The following is a description of a gene set: species: Homo sapiens Human Gene Set: GSE14769_20MIN_VS_360MIN_LPS_BMDM_UP The innate immune system is a two-edged sword; it is absolutely required for host defense against infection, but if left uncontrolled can trigger a plethora of inflammatory diseases. Here we used systems biology approaches to predict and validate a gene regulatory network involving a dynamic interplay between the transcription factors NF-κB, C/EBPδ, and ATF3 that controls inflammatory responses. We mathematically modeled transcriptional regulation of Il6 and Cebpd genes and experimentally validated the prediction that the combination of an initiator (NF-κB), an amplifier (C/EBPδ) and an attenuator (ATF3) forms a regulatory circuit that discriminates between transient and persistent Toll-like receptor 4-induced signals. Our results suggest a mechanism that enables the innate immune system to detect the duration of infection and to respond appropriately. Genes up-regulated in comparison of macrophage cells stimulated with LPS (TLR4 agonist) for 20 min versus macrophage cells stimulated with LPS (TLR4 agonist) for 360 min. from publication Litvak V, Ramsey SA, Rust AG, Zak DE, Kennedy KA, Lampano AE, Nykter M, Shmulevich I, Aderem A (PMID 19270711), and this is the list of marker genes: NME4 (NCBI Gene Id 4833), JPT2, DPP8, SPDL1, PLIN2, DYM, ORC2, LYL1, PSRC1, SELENBP1, TYROBP, PTGR2, ANAPC7, DTYMK, ANGPTL2, IMPA1, MAF1, NT5C, SAMM50, POP5, AKR1B1, AP5S1 (NCBI Gene Id 55317), BET1, NXT2, MBP, WDR7, CAMK1, PPP5C, BTBD3, CXorf38, EVI5, FDXR, GNA12 (G protein subunit alpha 12), NCAPD2 (NCBI Gene Id 9918), FAM78A, ZDHHC3, FBXL17, SLC35E2B, NSD2, GINS3, ANTXR2, FRRS1, TRIM44 (tripartite motif containing 44), RAB3IL1, NEIL3, ARHGDIB, CASP2 (caspase 2), BAG4, CRTAP, IARS1, LIPA, WDR5, EBPL, IGHM, PIK3CG, COMMD10, E2F1, SLC41A2, G3BP1, MFSD12, GORASP1, APOO, EEF1B2 (eukaryotic translation elongation factor 1 beta 2), POLG2, KIAA0930, EEF2K, CYP20A1, CMC2, PXMP4, S100A6, PHKA2, OTUD6B, DYRK1A, CTSA, IGF1, TIMM21, ZBTB14, HADH (hydroxyacyl-CoA dehydrogenase), ZZZ3, CLN8, MDH1, PUS1, ATP11C, TM6SF1, CNOT8, CDIN1, RAB11FIP2, AP2S1, NCAPH, ING2, STN1, MRPS33, WFIKKN1, MCM4, SLC39A12, MLF1, KCTD17, CD9, NQO2, NDUFS1, HAUS1, PSPH, GNAQ, PDCL, USP28, POLD1, CCDC47, SEPHS2, PDLIM4 (NCBI Gene Id 8572), TSFM, SDHA, TUBE1, ACAT1, TMEM97, FKBP1A, NAV2, MCEE, TSEN2, RPS2, ATP6V0D2, CDK19, PRPSAP2, SLF1, IFTAP, UBE2U, SUOX, POLR2F, SNCAIP, LPCAT3, ASF1B, DDI2, INTS10, VTI1B, COX7A2, ATP5F1C, ENTPD4, MKNK1, GOLIM4, DHODH, DOCK1, POLR3G, PTPN18, TSPAN5, MXD4, NDUFA4, CLCC1, GLUD1, KCNAB2, ETFDH, GEMIN2, RAD51, GLA, RTF1, HMOX1, FAM118B, OSGEPL1, CSRP2 (cysteine and glycine rich protein 2), SMAD1, VPS26C, PRADC1, RNF141, MPC2, RPL9, DHX32, GRAMD2B, EYA1, DHRS1, NARS2, BBS7, WDR75, MEAF6, WIPI2, RFC4, CDC123, IFT80, ABCB7, PLPBP, MCCC2, MELK, GGH, CTNS, SNX9 (NCBI Gene Id 51429), IDH3B, ENTREP3, KCNK6, PGM2, HSPA9, ZBTB1, SARS1, ABCC3, GPR65 (G protein-coupled receptor 65), APEX1, FBLIM1, FAM111A, COQ9, ALDOA, NUP205, CCNDBP1, FAM170B, CNOT9